Given this list of marker genes CCDC66, VPS4B, ARF6, KIF14, PDCD6IP, OR2A4, EXOC2, EXOC6, CHMP4C (charged multivesicular body protein 4C), STK17B, USP3, KIF23, C9orf72 (C9orf72, member of C9orf72-SMCR8 complex), AGAP2, EXOC1, CEP55, CELF2, VPS4A, RACGAP1, IL16, IST1, EXOC7, ZFYVE19, TSG101 (tumor susceptibility 101), EXOC4, ANKRD45, FOXL2, RALA, DCDC1, CAPG, MICAL3, RAN, NUP62, CNTRL, BIRC6, here is a description of the gene set: Human Gene Set: GOCC_FLEMMING_BODY species: Homo sapiens A cell part that is the central region of the midbody characterized by a gap in alpha-tubulin staining. It is a dense structure of antiparallel microtubules from the central spindle in the middle of the intercellular bridge.